The following is a description of a gene set: Mouse Gene Set: GOMF_ACID_PHOSPHATASE_ACTIVITY species: Mus musculus Catalysis of the reaction: an orthophosphoric monoester + H2O = an alcohol + phosphate, with an acid pH optimum., and this is the list of marker genes: Acp3, Acp2, Acp4, Acp5, Minpp1, Acp7, Acp6, Acp1, Mdp1